Given this list of marker genes ATL1, SPTLC1, ATL3, DMXL2, SPTLC2, here is a description of the gene set: studied in species Homo sapiens The presence of reduced conduction velocity of motor nerves on electromyography. Human Gene Set: HP_EMG_SLOW_MOTOR_CONDUCTION EMG: slow motor conduction